Given this list of marker genes OCA2, SNRPN, MAGEL2, PDSS1, NDN (necdin, MAGE family member), NEXMIF, here is a description of the gene set: Bulimia studied in species Homo sapiens A form of anomalous eating behavior characterized by binge eating is followed by self-induced vomiting or other compensatory behavior intended to prevent weight gain (purging, fasting or exercising or a combination of these). Human Gene Set: HP_BULIMIA